The following is a description of a gene set: Human Gene Set: GOBP_POSITIVE_REGULATION_OF_SYNAPTIC_TRANSMISSION Any process that activates or increases the frequency, rate or extent of synaptic transmission, the process of communication from a neuron to a target (neuron, muscle, or secretory cell) across a synapse. species: Homo sapiens, and this is the list of marker genes: STX1A, MIR545, KMO, SLC18A3, MIR320D2, GRIN1, NR2E1, GRIA1, NLGN1, MIR320B2, CRHR2, MIR320C1, MIR342, EPHA4, PTN, ADORA1, TACR2, RETN, SYT12, SLC24A1, KCTD13, TNR, CACNG4, MIR433, CHRNA7, NPTN, ARRB2, ABL1, STX4, DRD2, CCR2, GRIN2D, MIR320D1, CALM1, RGS14, LARGE1, FAM107A, RAB3GAP1, MICU3, BRAF, SYT1, GPER1, STX1B (syntaxin 1B), NSG1, SQSTM1, SLC4A8, TSHZ3, C22orf39, CRH, NTRK2, ADORA2A, SHISA7, STAU1, SLC8A2, INS, ZDHHC12, PDE9A, CA2, CA7, HAP1, AGER, APOE, LGI1, TNF, KIF5B (kinesin family member 5B), EIF2AK4, ADCY8, CAMK2D, SNAP25, GRIN2B, SHANK2, MAPK1, IGSF11, CYP46A1, S100B, CREB1 (cAMP responsive element binding protein 1), SLC8A3, GRIN2C, NFATC4, MIR324, YTHDF1, ITPR3, NLGN2, ADCY1, CACNG2, MIR95, OXT, MIR337, SNCA (NCBI Gene Id 6622), PLK2, RELN, NRXN1, LRRTM2, STX3, MIR421, SLC1A3, VAMP2, CAMK2B, STXBP1, GSK3B, FMR1, CLSTN3, RAPSN, PPP3CA, MIR320A, APP, CACNG5, BAIAP3, PRKCZ, MME, ZDHHC3, CALM3, EPHB2, CAMK2G, CAMK2A, DTNBP1, NRGN, NLGN3, CACNG7, NCSTN, GRIA3, NF1, LGMN, CCL2, TAC1, LRRTM1, PRNP, GFAP, GRIK2, TYROBP, TACR1, PRKAR1B, FLOT1, NMU, ADRA1A, SHANK3, PRKCG, LAMA2, CACNA1B, BGLAP, CLSTN2, MIR541, MIR30B, LILRB2, MPP2, RASGRF2, MIR320C2 (microRNA 320c-2), PAIP2, PRRT1, CLSTN1, SERPINE2, NALCN, HDAC6, MIR320B1, GPR158, DRD1, CACNG3, SLC1A1, ARC, MECP2, AKAP5, HMGCR, MIR320E, PRKCE, SLC7A10 (NCBI Gene Id 83251), DLG4 (discs large MAGUK scaffold protein 4), GRIN2A, NPS, NOG, PTK2B, SLC24A2, NTRK1, FXR1, SLITRK4, CACNG8, ZDHHC2, IQSEC2, PINK1, CALM2